The following is a description of a gene set: Mutation-inactivated PINK1 to intrinsic apoptotic pathway. Pathway ID: N01050. Pathway type: Variant. Pathway class: nt06463 Parkinson disease. Pathway Definition from KEGG: PINK1* // PRKN // BAX -> CYCS == APAF1 -> CASP9 -> CASP3 Human Gene Set: KEGG_MEDICUS_VARIANT_MUTATION_INACTIVATED_PINK1_TO_INTRINSIC_APOPTOTIC_PATHWAY_N01050 species: Homo sapiens, and this is the list of marker genes: CYCS, BAX, CASP9, CASP3, PRKN, APAF1, PINK1